Given this list of marker genes MAPK1, IL6ST, TYK2, IL6R, JAK1, MAP2K2, PTPN11, IL6, JAK2, here is a description of the gene set: part of: RAF-independent MAPK1/3 activation Reactome Pathway: MAPK1 (ERK2) activation Mitogen-activated protein kinase kinase MAP2K2 (also known as MEK2) is a dual threonine and tyrosine recognition kinase that phosphorylates and activates MAPK1 (ERK2). species: Homo sapiens